The following is a description of a gene set: An adaptor that brings together an enzyme and its substrate. Adaptors recruit the substrate to its enzyme, thus contributing to substrate selection and specificity. Mouse Gene Set: GOMF_ENZYME_SUBSTRATE_ADAPTOR_ACTIVITY species: Mus musculus, and this is the list of marker genes: Klhdc3, Klhl28, Oog4, Fem1al, Klhl22, Klhl35, Fbxw8, Pramel46, Pramel5, Herpud1, Pramel27, Hpf1, Klhdc10, Pramel31, Zswim8, Pramel22, Pramel47, Rbm47, Pramel57, Pramel28, Vhl, Fbxl2, Gan, Pramel20, Rragc, Oog3, Fem1a, Klhl18, Lrrc75a, Axin1, Pramel15 (NCBI Gene Id 627009), Pramex1, Nmnat1 (nicotinamide nucleotide adenylyltransferase 1), Rbp2, Klhl30, Pramel41, Chm, Pramel59, Klhl1, Pramel33, Wdr77, Kctd17, Pramel30, Ppp2r2a, Fbxo11, Rictor, Asb11, Pnkp, Pramel56, Det1, Kbtbd2, Keap1, Pramel13, Mapkap1, Pramel45, Pramel60 (PRAME like 60), Oog1, Fbxo9, Pramel17, Kbtbd8, Pramel51, Pramel39-ps, Pramel24, Fbxo45, Dcaf1, Arrdc1, Fem1b, Pramel7, Socs7, Dcaf13, Pramel34, Pramel48, Kbtbd12, Dcaf12, Paqr3, Pramel11, Pramel18, Klhl10, Kbtbd7, Kbtbd6, Ivns1abp, Klhl7, Klhl41 (NCBI Gene Id 228003), Pramel49, Trpc4ap, Nmnat2, Spsb3, Sh3bgrl, Pramel25, Klhl8, Fbxo4, Klhdc2, Kbtbd3, Pcmtd1, Ppp2r2d, Skp2, Fbxw7, Pramel32, Klhl23, Klhl17, Spsb2, Klhl6, Spsb1, Pramel38, Pramel19 (PRAME like 19), Pdcd6, Klhl3, Suv39h2, Pramel43, Fbxo3, Asb1, Oog2, Klhl24, Klhl15, Pef1, Pramel12, Ankrd9, Fzr1, Ccin, Pramel44, Klhl29, Fbxo38, Anapc7, Pramel26, Pramel16, Epc1, Daw1, Pramel42, Pramel50, Socs2, Btrc, Pramel37, Fbxl4, Klhl4, Pramel53, Ambra1, Pramel29, Klhl25, Pramel21, Pramel23, Asb9, Dtx3l, Rptor, Cdk5rap3, Arrdc4, Pramel1, Klhl21, Skp1, Klhl40, Smad7, Pramel40, Fbxl19, Pramel36, Klhl38, Fbxo7, Pramel14, Gfi1, Pramel35, Fbxo42, Pramel54, Fbxw11, Gm13040, Tut1, Klhl12, Spsb4, Ipp, Klhdc1, Klhl11, Pramel6, Appbp2, Pramel61, Pramel55, Cdc20 (NCBI Gene Id 98038), Klhl20, Klhl2, A1cf, Fem1c, Klhl5